Given this list of marker genes Akr1c20, Cyp3a11 (cytochrome P450, family 3, subfamily a, polypeptide 11), Cyp3a25, Cyp3a13, Cyp3a41b, Ugt2b38, Ugt2b34, Hsd11b2, Ugt2b37, Abcb1a, Ugt2b5 (NCBI Gene Id 22238), Akr1c21, Ugt2b1, Cyp3a41a, Cyp3a44, Ugt1a5, Alb, Serpina6, Cyp3a16, Cyp3a57, Hsd11b1, Ugt1a2, Ugt2b35, Akr1c6, Cyp3a59, Ugt2b36, here is a description of the gene set: studied in species Mus musculus Prednisone ADME Mouse Gene Set: REACTOME_PREDNISONE_ADME